The following is a description of a gene set: Any process that stops, prevents, or reduces the frequency, rate, or extent of type I interferon production. Type I interferons include the interferon-alpha, beta, delta, episilon, zeta, kappa, tau, and omega gene families. species: Homo sapiens Human Gene Set: GOBP_NEGATIVE_REGULATION_OF_TYPE_I_INTERFERON_PRODUCTION, and this is the list of marker genes: MIR26B, ILRUN, CUL3, GBP7, PTPN11, KLHL22, QKI, PPM1B, BANF1, ITCH, CACTIN, LILRB1 (leukocyte immunoglobulin like receptor B1), REL, MORC3 (NCBI Gene Id 23515), KAT8, GPATCH3, ATG9A, DDX56, IL10, MIR21, NLRC3, CYLD, LILRA4 (leukocyte immunoglobulin like receptor A4), TYROBP, ACOD1, TRAIP, UFD1, PTPRS, NPLOC4, SIRPA, ATG5, TRIM27, NMI, RELB, RBX1, RNF216, HAVCR2, IRGM, PYCARD, YY1, ATG12, NLRX1, XAF1, TRAF3IP1, SIGLEC1, RNF125, OTUD5, DHX58